Given this list of marker genes Cdo1, Xkrx, Zfp459, Socs6 (suppressor of cytokine signaling 6), Crisp4, Zfp970, Mmachc, Noto, Ube3a, Il22ra2, 2210418O10Rik, Strn3, Fndc4, Nos1, Zbtb20, Trp53rkb, Sting1, Grm3, Pou2af3, Zfp781b, Ap5s1, Gm14296 (predicted gene 14296), Zfp1009, Itm2a, Exph5 (exophilin 5), Pnrc2, Gnl3l, Tomm70a, Radx, Edaradd, Gpr141b (G protein-coupled receptor 141B), here is a description of the gene set: Genes predicted to be targets of miRBase v22 microRNA mmu_miR_296_3p in miRDB v6.0 with MirTarget v4 prediction scores > 80 (high confidence targets). studied in species Mus musculus from publication Chen Y, Wang X (PMID 31504780) Mouse Gene Set: MIR_296_3P